The following is a description of a gene set: Glucuronidation studied in species Mus musculus Mouse Gene Set: WP_GLUCURONIDATION, and this is the list of marker genes: Pgm2, Ugt2a1, Ugt1a8, Ugt1a10, Ugt2b1, Ugdh, Ugt1a1, Ugt1a2, Pgm1, Ugp2, Ugt1a5, Ugt2b34, Hk1, Pgm3, Ugt2a2 (NCBI Gene Id 552899), Pgm5 (phosphoglucomutase 5), Ugt2a3